The following is a description of a gene set: Genes predicted to be targets of miRBase v22 microRNA hsa-miR-4456 in miRDB v6.0 with MirTarget v4 prediction scores > 80 (high confidence targets). Human Gene Set: MIR4456 from publication Chen Y, Wang X (PMID 31504780) studied in species Homo sapiens, and this is the list of marker genes: TXLNA, FZR1, ASXL1, GABBR2, SMURF1, MRPL3, ZNF773, SLC24A2, NFAT5, GALNT10, ACTN1, RGL1, STPG1, PPM1H, TMEM101, ADCYAP1R1, SENP1, HGSNAT, SHFL, IKZF3, ZNF609, GNB1, OBP2A, ZNF275 (zinc finger protein 275), NFIA, SLC25A25, PDIA3, CCL4L2 (C-C motif chemokine ligand 4 like 2), RPS6KL1, FAM170B, MTCL3, ZNF131, CNOT8, ZBTB43, EFNB3, MAN1A1, PRAMEF13, SMG1 (SMG1 nonsense mediated mRNA decay associated PI3K related kinase), PHF21A, ZNF74, EXOC4, KPNA4, ZNF589, ADCY1, LY6G5C, ERC1, BBX, GPX5, GSE1, PCNP, INTS10, MED26, PTPRF, TIGAR, ZNF135, DIP2C, MECP2, TMEM39B, PTK2, LGALS3BP, PLEKHG4B, MXD1, MTCL2, PPIA, BAHCC1 (BAH domain and coiled-coil containing 1), ZNF268, DBNDD2, FOXN4, SGCB, SLC13A4, VSIG4, FIBP, ZMAT4, ZNF282, URM1, ZNF584, TAPT1, MAFA, TRPS1, RUVBL2, CACNA1C, CD40, PRDM11, PRKACA, TACR2, SORBS2, ZNF711, KLHL20, SLC9A1, EPHA7, LZTS1, TMEM184B, SEPTIN7, SOHLH2, RANBP10, GPATCH2, METTL8, TMEM134, PYGB, ZDHHC21, UBE2V1, C2CD2, DYRK4, VCF1, GLP2R (glucagon like peptide 2 receptor), PML, SHISA7, PRRC2B, KPNA3, BNC2, XPO7, CHD6, MLXIP, SRRM4, PRAMEF14, PHOX2B, ZNF839, CACNA2D2, C17orf78, ENTREP2, FOXP4, MYCN, CALML4, PPIP5K1, CNTNAP3, CNNM1, RNF38, PDGFRB, OBP2B, GPR158, MARK2, GPATCH2L, TBC1D8B